The following is a description of a gene set: species: Homo sapiens The progression of a growth plate cartilage chondrocyte over time from after its fate commitment to the mature cell. Human Gene Set: GOBP_GROWTH_PLATE_CARTILAGE_CHONDROCYTE_DEVELOPMENT, and this is the list of marker genes: SOX9, COL27A1, POC1A, TGFBR2, TSKU, RARG